The following is a description of a gene set: Any process that stops, prevents, or reduces the frequency, rate or extent of cell activation. studied in species Mus musculus Mouse Gene Set: GOBP_NEGATIVE_REGULATION_OF_CELL_ACTIVATION, and this is the list of marker genes: Mertk, Ptpn2, Jak3, Cd274, Cd200, Tgfb1, Clec4g, Hmgb1, Nrarp, Pde5a, H2-T23, Lilrb4a, Lst1, Ihh, Pglyrp3, Lrfn5, Lrrc32, Cd24a, Pla2g2d, Pdcd1lg2, Cd74, Tbc1d10c, Cd37, Havcr2, Xcl1, Cx3cl1, Gpnmb (NCBI Gene Id 93695), Cd9, Il10, Irf1, Cblb, Inpp5d, Dlg5, Apoe, Cebpb, Gp5, Socs5, Axl, Dapl1, Tarm1, Vtcn1, Tnfrsf13b, Cd300a, Il4ra, Crtam, Ifnb1, Pf4, Ufl1, Ceacam1, Ubash3b, Nr1h3, Vsir, Tyro3, Fcgr2b, Itch, Zbtb7b, Cnr2, Enpp3, Glmn, Gper1, Prkg1, Tbx21, H2-Aa, Btla, Cdkn2a, Ptpn11 (protein tyrosine phosphatase, non-receptor type 11), Lag3, Prnp, Foxj1, Ndfip1, Ascl2, Il2, Alox12, Fgr, Twsg1, Nfkbid, Gclc, Tigit, Adgrf5, Mdk, Flt3, Tafa3, Zbtb46 (NCBI Gene Id 72147), Sdc4, Tmem131l, Bank1, Erbb2 (erb-b2 receptor tyrosine kinase 2), Cd80, Emilin1, Pla2g2f, Ptpn6, Pglyrp1, Adamts18, Rabgef1, Zc3h12d (zinc finger CCCH type containing 12D), Rian, Tnfrsf21, Prkcd, Tsc2, Cst7 (NCBI Gene Id 13011), Gal, Loxl3, Gli3, Cd69, C1qtnf1, Hfe, Ctla4, Pdgfra, Laptm5, Prkar1a, Zfp608 (zinc finger protein 608), Lax1, Prdx2, Cd86, Samsn1, Tnfsf18, Cd84, Runx3, Pparg, Dusp3 (dual specificity phosphatase 3 (vaccinia virus phosphatase VH1-related)), Il20rb, Arg2, Fgl1, Rag2, Fam76b, Bcl6, Smad7, Hspb1, Src, Sh2b3, Pdcd1, Rassf5, Scgb1a1, Pkn1, Pdgfb, Anxa1, Rc3h1, Pag1, Pten, Il4, Tnfrsf14, Nr1d1, Cd44, Rhbdd3, Zc3h12a, Ldlr (NCBI Gene Id 16835), Fn1, Tnfsf4, Serpine2, Milr1, Pglyrp2, Arg1, Id2, Gnrh1, Atm, Lgals9, Dusp22 (NCBI Gene Id 68676), Cnr1, Btn2a2, Sfrp1, Dlg1, Pla2g5, Cygb, Pdgfa, Slfn1, Lyn, Pla2g2a, Tspan32, Dtx1, Tnfaip3, Pawr, Fas, Scrib, Vsig4, Hlx, Socs1, Adora2a, Ido1, Marchf7, Tyrobp, Spn, Mad1l1, Clnk (cytokine-dependent hematopoietic cell linker), Sftpd, Zfp35, Shh, Rc3h2, Slc4a2, Zc3h8, Bpi, Tmx1, Il4i1, Cbfb, Grn, Fer, Cd300lf, Peli1, Socs6, Bmp4, Tnfaip8l2, Syt11, Btk, Sox11, Fbxo7, Parp3, Hmgb3 (NCBI Gene Id 15355), Cd276, Gimap3, Fgl2, BC037156, Gimap5, Runx1, H2-M3, Tff2, Ctsg, Lilrb4b, Lgals1, Ripor2, Casp3, Clec12a, Pibf1, Ptpn22, Pglyrp4, Foxp3, Mill1, Ildr2, Lgals3 (NCBI Gene Id 16854), Trem2, Il2ra